The following is a description of a gene set: Genes down-regulated in quiescent (G0) CD34+ cells isolated from peripheral blood of CML (chronic myeloid leukemia) patients compared to the quiescent cells from normal donors. Quiescent and dividing hemopoietic stem cells (HSC) display marked differences in their ability to move between the peripheral circulation and the bone marrow. Specifically, long-term engraftment potential predominantly resides in the quiescent HSC subfraction, and G-CSF mobilization results in the preferential accumulation of quiescent HSC in the periphery. In contrast, stem cells from chronic myeloid leukemia (CML) patients display a constitutive presence in the circulation. To understand the molecular basis for this, we have used microarray technology to analyze the transcriptional differences between dividing and quiescent, normal, and CML-derived CD34+ cells. Our data show a remarkable transcriptional similarity between normal and CML dividing cells, suggesting that the effects of BCR-ABL on the CD34+ cell transcriptome are more limited than previously thought. In addition, we show that quiescent CML cells are more similar to their dividing counterparts than quiescent normal cells are to theirs. We also show these transcriptional differences to be reflected in the altered proliferative activity of normal and CML CD34+ cells. Of the most interest is that the major class of genes that is more abundant in the quiescent cells compared with the dividing cells encodes members of the chemokine family. We propose a role for chemokines expressed by quiescent HSC in the orchestration of CD34+ cell mobilization. Disclosure of potential conflicts of interest is found at the end of this article. studied in species Homo sapiens from publication Graham SM, Vass JK, Holyoake TL, Graham GJ (PMID 17717066) Human Gene Set: GRAHAM_CML_QUIESCENT_VS_NORMAL_QUIESCENT_DN, and this is the list of marker genes: SCHIP1, HLA-DPA1, TGFB1I1, SPTBN1, HLA-DMB, CRHBP, CXCL1, PROM1, SORL1, FAM30A, HLX, AIF1, HLA-DQB1, GLIPR1, EMP1, LIMCH1, ALOX5, ADGRG6, HLA-DMA, GUCY1A1, CXCL6, RBPMS, SELL, CD52, TSPAN6, TM4SF1, BAALC, MPZL2, PCDH9, HLA-DRB4, PMCH (NCBI Gene Id 5367), AREG, MLLT3, APP, HLA-DQA1, VNN1, HLA-DPB1, DUSP6, PPFIBP1, SPINK2, FHL1, HLF, H1-0, IDS, GBP2, H2BC21